Given this list of marker genes F2RL1, EPAS1, MANSC1, SS18, STEAP4, KCNT2, WIF1, BMS1, GRM3, KLHL21, LINC00622, MKNK1-AS1, PLPP3, TGFBRAP1, RPL6, STAT5B, CFAP73, RUNDC3B, TOP1MT (DNA topoisomerase I mitochondrial), FRMD6, DDR2, NSUN7, MMGT1, DAB2IP, IL24 (interleukin 24), SLC30A4, RSPH1, CXCL1, DMRTA2, STK16, FBXL13, ERLEC1P1, ZNF830, KDM4D, UNC119B, ACOX1, IGF2R, ZDHHC18, PEX12, TSG101, CCDC28A, LHX5 (NCBI Gene Id 64211), ETNPPL, SLC26A3, HSPA9, ZNF586, EIF3L, BTF3, KLHDC2, WEE2-AS1, ELAPOR1, CCT3, ANKHD1, SERTAD4, DBIL5P, DCLK1, IPO5 (NCBI Gene Id 3843), MMP9, GJB6, VAT1, MYO10, DMRTC2, PRKAA2, CCDC68, ALPK2, IL1R1 (NCBI Gene Id 3554, interleukin 1 receptor type 1), GABRB1, ORM1, PTPN14, SH3GLB1, CYB5D2, KANK4, CNTNAP3, CXCR2, SYTL3, KIT, ANGPT1, RBBP5, SLC6A14, CDHR2, PLEKHN1, ITGAE, ICAM3, TNFRSF10C, FXR1, CFAP45, MPPED2, JADE1, CXCL6, TMEM178B, PIK3CA, CHAMP1, LITAF, USP3-AS1, PNRC1, JRK, TMEM184A, CNIH2, IBA57, FOS, DANCR, KDM5B, PI3, DAPK2, TPTE2P6, STK4, FCRL4, MMP8, MARVELD3 (NCBI Gene Id 91862), ATOSA, CELF5, SDC2, TMCC3 (transmembrane and coiled-coil domain family 3), GPR161, CLDN1, TH, WNT5A, ARCN1, TMEM43, OLFM4, EFNA1, PRKY, KCNJ15, VIRMA, GPR75, NTN4, CYP4F3 (NCBI Gene Id 89256), DYRK2, DGAT2, NACC1 (nucleus accumbens associated 1), RNF182, SLC13A1, ARG1, RP1, RPL23AP53, MME, SYT8, CHP1, EIF3LP3, GNAT1, FRAT2, RARA, OR2L13, FAM186A, DPPA4, IL1RAP, GLT1D1, NIBAN1, TPRG1L, ADGRG3, CRKL, TBC1D14, MKRN7P, TENM2, MTMR3, UBE4B, ASB8, TGFA, ANTXR2, CRYBA1, VNN3P, CCR3, PPP4R1, HTRA4, TCP11L2, MPZL3, FRAT1, ITGB8, ASB2, IQCF5, PAK2, TEAD1, NRIP1, PDRG1, ZNF430, MAN2A2, ADCY4, SYS1, ZFP30, ENSG00000187186, THSD7A, ZNF669, RFLNB, AQP9, LHFPL3, CHI3L1, UGT2B28, CA4, FAT3, ATP8B1, SPOCK2, here is a description of the gene set: from publication Querec TD, Akondy RS, Lee EK, Cao W, Nakaya HI, Teuwen D, Pirani A, Gernert K, Deng J, Marzolf B, Kennedy K, Wu H, Bennouna S, Oluoch H, Miller J, Vencio RZ, Mulligan M, Aderem A, Ahmed R, Pulendran B (PMID 19029902) Human Gene Set: GSE13485_PRE_VS_POST_YF17D_VACCINATION_PBMC_UP The immune responses generated by YF-17D by profiling genes in 25 vaccine recipients were accessed at days 1, 3, 7, and 21 post-vaccination compared to pre-vaccination in PBMCs. The immune responses generated by YF-17D by profiling genes in 25 vaccine recipients were accessed at days 1, 3, 7, and 21 post-vaccination compared to pre-vaccination in PBMCs. Genes up-regulated in comparison of peripheral blood mononuclear cells (PBMC) before vs after YF17D vaccination. studied in species Homo sapiens